Given this list of marker genes Chkb, Snai3, Otub2, Btbd1, Plod1, Arpp19 (cAMP-regulated phosphoprotein 19), Eno3 (NCBI Gene Id 13808), Pias3, Cdc20, Cep15, Gcat, Ube3b, Eif3c, Tk1, Zcwpw1, Scyl1, Fuom, Ciz1, Dcxr, Ankrd13a, Evc, Ccdc28b, Naa80, Pard6a, Rars2, Cotl1, Gna11, Nt5c3b, Cul7, Wdr90, Sox15, Slc28a1, Strip1, Haghl, Ints11, Tfdp1, H3f3a (NCBI Gene Id 15078), Myd88, Lrfn3, Ndufb11b, Fhip1b, Krba1, Zfp579, Nme3, Drg2, Dhodh, Sdhaf1, Wars1, Tmem186, Grk6, Vps45, Ap2m1, Celf4, Katnip, Itga3, Atp2a3, Gm9918, Atp11b, Rnf225, Tubgcp2, Slc6a9, Nt5e, Ddx27, Lztr1, Ampd3, Krt7, Idh3a, Pbx2, Rac3, Mslnl, Nadk, Tcea3, Arg2, Mzt2, Shc1, Plcd1, Bcam, Sfswap, Cpb2, Agfg1, Cpe, Fam110a, Bckdha, Irf2bp1, Trmt1l, Urah, Dnajc7, Snn, Rarres2, Qars1, Slc25a44, Lrrc40, Sap30, Npepl1, Ppp1r14d, Fkbp6, Ykt6, Sgcb, Cwc22, Fastk, Pou2f1, F2r, Rarg, B4gat1, Rbks, Gfpt2, Akap9, Rapgef3, Taf5, Cc2d2a, Tmem131 (transmembrane protein 131), Ltbp3, Rtl6, Baiap2, Dgkq, Aplp1, Kdm4b, Spryd4, Ptpa (NCBI Gene Id 97035), Ndst2, Rpp25l, Triobp, Mrpl10, Crip2, Rdm1, Wipi2, Rps6ka4, Gtpbp2, Cox6a2, Sec14l1, Riok3, Scly, Pola2, Blcap, Elac1, 2310022B05Rik, Rnmt, Ift172, Ruvbl2, Cplx1, Tnrc6c, Tgm2, Sub1, Etfbkmt, R3hdm4, Bdh2, Dusp11, Dnd1, Pgls, Rassf1, Acad10, Ddx25, Gli2, Pik3r2, Ciart, Lrch4, Il11ra1, Ankzf1, Trabd, Ctbp2, Vrk1, Mthfd2, Pex11a, Gfm2, Celsr3, Foxn4, Adap1 (NCBI Gene Id 231821), Kdm1a, Ankmy2, Coro1a, Spata24 (NCBI Gene Id 75944), Nisch, Abcb6, Dis3l, Gnptg, Ube2e1, Phykpl, Naprt, Rccd1, Metrn, Ap1b1, Tmem141, Mrpl35, Tia1, Zfp810, Diras1, Snx17, Tet2, Ubr7, Ddit3 (NCBI Gene Id 13198), Poldip2, Tbc1d2, Itgb4, Tgm1, Echs1, Nos3, Bub1b, Ube2d3, Acot8, Dlgap5, Ankra2, Elmo3, Gng13, Nat8f1, here is a description of the gene set: Genes down-regulated in ES cells (embryonic stem) heterozygotic for KDM1A loss of function mutant compared to the homozygotic loss of the gene. from publication Foster CT, Dovey OM, Lezina L, Luo JL, Gant TW, Barlev N, Bradley A, Cowley SM (PMID 20713442) Mouse Gene Set: FOSTER_KDM1A_TARGETS_DN Lysine-specific demethylase 1 (LSD1), which demethylates mono- and dimethylated histone H3-Lys4 as part of a complex including CoREST and histone deacetylases (HDACs), is essential for embryonic development in the mouse beyond embryonic day 6.5 (e6.5). To determine the role of LSD1 during this early period of embryogenesis, we have generated loss-of-function gene trap mice and conditional knockout embryonic stem (ES) cells. Analysis of postimplantation gene trap embryos revealed that LSD1 expression, and therefore function, is restricted to the epiblast. Conditional deletion of LSD1 in mouse ES cells, the in vitro counterpart of the epiblast, revealed a reduction in CoREST protein and associated HDAC activity, resulting in a global increase in histone H3-Lys56 acetylation, but not H3-Lys4 methylation. Despite this biochemical perturbation, ES cells with LSD1 deleted proliferate normally and retain stem cell characteristics. Loss of LSD1 causes the aberrant expression of genes, including those coding for transcription factors with roles in anterior/posterior patterning and limb development, such as brachyury, Hoxb7, Hoxd8, and retinoic acid receptor γ (RARγ). The gene coding for brachyury, a key regulator of mesodermal differentiation, is a direct target gene of LSD1 and is overexpressed in e6.5 Lsd1 gene trap embryos. Thus, LSD1 regulates the expression and appropriate timing of key developmental regulators, as part of the LSD1/CoREST/HDAC complex, during early embryonic development. studied in species Mus musculus